The following is a description of a gene set: Genes that physically map to the hematopoietic stem cell (HSC) proliferation QTL (quantitative trait locus) Scp2. Mouse Gene Set: BYSTRYKH_SCP2_QTL studied in species Mus musculus We combined large-scale mRNA expression analysis and gene mapping to identify genes and loci that control hematopoietic stem cell (HSC) function. We measured mRNA expression levels in purified HSCs isolated from a panel of densely genotyped recombinant inbred mouse strains. We mapped quantitative trait loci (QTLs) associated with variation in expression of thousands of transcripts. By comparing the physical transcript position with the location of the controlling QTL, we identified polymorphic cis-acting stem cell genes. We also identified multiple trans-acting control loci that modify expression of large numbers of genes. These groups of coregulated transcripts identify pathways that specify variation in stem cells. We illustrate this concept with the identification of candidate genes involved with HSC turnover. We compared expression QTLs in HSCs and brain from the same mice and identified both shared and tissue-specific QTLs. Our data are accessible through WebQTL, a web-based interface that allows custom genetic linkage analysis and identification of coregulated transcripts. from publication Bystrykh L, Weersing E, Dontje B, Sutton S, Pletcher MT, Wiltshire T, Su AI, Vellenga E, Wang J, Manly KF, Lu L, Chesler EJ, Alberts R, Jansen RC, Williams RW, Cooke MP, de Haan G (PMID 15711547), and this is the list of marker genes: Ccl9, Lig3, Psmb6, 6330403K07Rik, Kif1c, Ggnbp2, Mpo